Given this list of marker genes NUP160, ALYREF, SLBP, SEC13, TPR, NUP43, NUP62, NUP35, NXF1, NUP50, EIF4E, NUP188, POM121C, NUP107, NUP98, NUP37, NUP42, POM121, NUP210, NDC1, NUP205, NUP54, NUP93, NCBP1, RAE1, RANBP2, NUP155, NUP58, NUP214, SEH1L, AAAS, NUP153, NUP133, NUP85, NCBP2 (NCBI Gene Id 22916), NUP88, here is a description of the gene set: Transport of the SLBP Dependant Mature mRNA studied in species Homo sapiens Human Gene Set: REACTOME_TRANSPORT_OF_THE_SLBP_DEPENDANT_MATURE_MRNA